The following is a description of a gene set: Binding to a GTPase, any enzyme that catalyzes the hydrolysis of GTP. species: Mus musculus Mouse Gene Set: GOMF_GTPASE_BINDING, and this is the list of marker genes: Ppp1r9a, Dock11, Rasgrp3, Gga1, Rasgrf1, Lsm2, Eprs1, Rabggtb, Ect2, Fmnl2, Git2, Acap2, Diaph3, Trip11, Ipo11, Gas8 (NCBI Gene Id 83455), Stoml2, Gdi2, Ap1g1, Golga4, Rims4, Pak3, Adcyap1r1, Gdi1, Kif16b, Itpka, Bicd1, Nutf2, Nox1, Tbc1d21, Rock2, Als2cl, Kctd13, Pot1b, Ulk1, Cyfip2, Rab3ip, Sptbn1, Evi5l, Bicdl2, Cdc42ep3, Rac1, Strn3, Birc5, Ralbp1, Bcl2l1, Fmnl3, Dennd1a, Dock4, Erc1, Iqgap1, Sorl1, Tbc1d20, Exoc5, Ipo5, Srgap1, Tbc1d7, Dock9, Brk1, Gga2, Rab11fip1, Rinl, Rab7, Eno1, Strip1, Garre1, Rragb, Dock7, Hps4, Arhgef7, Rap1a, Arhgdib, Cav1, Sgsm2, Tnfaip1, Sytl1, Ybx1, Cyfip1, Cdc42se2, Rasip1, Rab8a, Bin1, Aimp1, Sytl3, Mical1, Daam1, Dock10, Xpo6, Arhgdia, Was, Als2, Iqgap2, Ipo8, Afdn, Cimap3 (NCBI Gene Id 76420), Myo5a, Rab11fip3, Xpo7, Srgap2, Nutf2-ps2, Dock3, Anxa2, Wdr44, Ngfr, Rgl3, Llgl1, Atp7a, Gria1 (glutamate receptor, ionotropic, AMPA1 (alpha 1)), Nutf2-ps1, Dennd1b, Ambra1, Rims1, Usp33, Atg16l1, Mapkap1, Chml, Dvl1, Rcc2, Atp6ap1, Cyrib, Sh3bp4, Dennd5b (NCBI Gene Id 320560), Ndrg1, Dgki, Arhgef16, Rabgap1, Lrrk2, Npc1l1, Cyria, Gnb1, Ncf2, Sike1, Yipf2, Ptprn, Mycbp2, Rbsn, Ehd1, Dennd5a, Mlph, Sgsm3, Rhobtb3, Coro1c, Gm14137 (predicted gene 14137), Kntc1, Fnbp1l (formin binding protein 1-like), Daam2, Wasf1, Inf2, Dvl2, Tbc1d13, Braf, Depdc5, Vps4a, Rap1gap, Abi2, Bnip3, Pkn3, Diaph1, Rilp, Arhgap44 (NCBI Gene Id 216831), Lamtor1, Plekhg1, Ranbp17, Plekhg3, Gga3, Nsf, Rin1, Dnm1l, Ranbp2, Noxa1, Fmnl1, Flna, Plk2, Vcl, Pfn1, Rgp1, Whamm, Exph5, Tnpo3, Ocrl, Sod1, Exoc2, Odf2, Radil, Ankfy1, Rragc, Rasa1, Map3k11, Prkch, Rab11fip4, Plekhg2, Cse1l, Rph3al, Rangap1, Ric1, Becn1, Ppp6r1, Rapgef6, Myo5b, Hdac3, Pde6d, Pard6a, Rab11fip2, Errfi1, Pak1, Rnf41, Fgd1, Golga5, Rusc2, Ankrd27, Rab34, Micall2, Kif3b, Stx4a, Ift20, Rims2, Lcp1, Tbc1d30 (TBC1 domain family, member 30), Ipo13, Unc13d, Yipf1, Rabgef1, Myo1c, Pkn2, Clta, Picalm, Rnf152, Atg14, Rapgef4, Rtkn, Ipo4, Tnpo2, Kif3a, Myo9b, Cdc42se1, Preb, Vps9d1, Pih1d2, Ccdc186, Cdc42ep1, Hsp90aa1, Tsc2, C9orf72, Ipo7, Arhgef2, Sytl2, Akap13, Rabggta, Nup153, Eno1b, Dennd10, Exoc8, Rph3a, Rilpl2, Xpo5, Sgsm1, Sytl4, Cdc42ep2, Rragd, Tamalin, Cdc42ep4, Bicd2, Pqbp1, Grip1, Usp6nl, Rcc1, Abca1, Tmem127, Xpo1, Micall1, Ranbp9, Sytl5, Myrip, Dock1, Rock1, Farp1, Plce1, Pex5l, Rabac1, Ipo9, Xpo4, Chm, Dvl3, Nckap1, Dapk3, Rilpl1, Rabgap1l, Kpnb1, Rangrf, Bicdl1, Cdc42bpb, Prkaca (NCBI Gene Id 18747), Rab3gap2, Cib1, Mfn2, Mff, Dmxl2, Cdkl5, Rassf1, Iars1, Eps8, Rims3, Rin3, Evi5, Iqgap3, Mtss2, Rab29, Hace1, Pak2, Marchf5, Ranbp10, Rab11fip5, Sh3gl1, Rptor, Diaph2, Pkn1 (protein kinase N1), Rin2, Pou4f1, Lztr1, Git1, Rab3gap1, Gnb3, Cdc42ep5, Xpot, Arhgap1, Tnpo1, Raf1, Hps6, Appl2, Gnb2, Dock2, Pex5, Nxt1, Dock5, Ap3m1, Gapvd1, Map2k1